The following is a description of a gene set: Genes up-regulated in comparison of untreated CD4 T cells at 0 h versus the untreated cells at 72 h. The aim of this dataset was to study in detail the transcription kinetics initiated by cytokine IL-4 in early differentiation of Th2 cells. studied in species Homo sapiens from publication Elo LL, Järvenpää H, Tuomela S, Raghav S, Ahlfors H, Laurila K, Gupta B, Lund RJ, Tahvanainen J, Hawkins RD, Oresic M, Lähdesmäki H, Rasool O, Rao KV, Aittokallio T, Lahesmaa R (PMID 20620947) Human Gene Set: GSE17974_0H_VS_72H_IN_VITRO_ACT_CD4_TCELL_UP, and this is the list of marker genes: ZNF844, HABP4, COQ10A, RFX3, CCDC86 (coiled-coil domain containing 86), C6orf226, GSAP, NFKBIZ, EGR1, ZNF394, ST3GAL5, SHISAL2A, MIR22HG, IL7R, MARCHF2, RNF11, SAMD4B, LGI1, ZDHHC11, CD83, RMND5A, PSMG4 (NCBI Gene Id 389362), ZBTB20, PRKCQ-AS1, ASAH1, HES4, RNF139, EID3, VCPKMT, TRPM7, WDR81, VIPR1, CLASRP, G0S2, LDB2 (NCBI Gene Id 9079), ST6GALNAC1, CXCL1, IPCEF1, TWNK, TSSC4, TTC28, FBXO33 (F-box protein 33), PRRX1, FCN1, SNX29, ITGA6, DNAJB9, TTN, TRIB2, MEF2D, PAIP1, CHD9, C16orf54, NSMCE3, CRAMP1, MAN2B2, RARS2, ITFG2, BIN2, PTPN13 (NCBI Gene Id 5783), TRAPPC14, SLC25A33, TRIB1, CTSO, TWF1, TNRC6B, NOSIP, PGAP3, APOBEC3A, VPS9D1, TRMT6, CLEC7A (NCBI Gene Id 64581), KRT73, ZNF669, TMEM132B, WDR53, EFHC2, MAP3K5, AK5, DGKQ, FBXL5, KANSL2, SOX6, CUX1, POLR3E (RNA polymerase III subunit E), ZNF256, TCTA, SMCR5, ATXN1L, DDX28, SNORD104, TENM1, METAP1D, TMEM9B, TNFSF8, ATP2B1-AS1, ZNF8, SMURF2, FCMR, USF3, CSGALNACT1, CIRBP, ITPRIP, SAXO5, GABBR1, MFSD1, KLF2, FHIT (fragile histidine triad diadenosine triphosphatase), UTP15, TSPYL4, YRDC, LILRB2, ENC1, PCSK5, YPEL5, NAP1L5, JUN, KLF11, TCF7L2, COQ10B, KLF4, IL1B, MORC2-AS1, LMTK2, ANKRD36C, RAPGEF1, SLC5A6, TPM2, IL11RA, LINS1, SGK1, ZNF592, ATP6V0A2, ANXA1, ERP27, FAM200B, C9orf78, TSPYL2, ENSG00000274253, STXBP5, SIK1, TAMALIN, PLXDC1, RNF125, SKIL, RAP1GAP2, ZNF542P, IRS2, IFT20 (intraflagellar transport 20), SYNM, PTP4A1, ZNF805, ZNF502, RRN3P1, RIOX1, ABHD13, LYZ, H3C1, L3MBTL3, LETM1, RNF10, ID2, AUTS2, ARIH2, TMEM201, SLC12A9, JADE1, RGS2, EPHA4, NR4A2, GABARAPL1, ARMC2, GADD45A, ANKRD52, TIGD1, FGF5, NOM1, TRIM16L, MARCHF8, TNFRSF21, ASPH, SLC25A25-AS1 (NCBI Gene Id 286208), DUSP1, HCK, PITHD1, ABL2, SNORA28, GPR153, PARP8, DGCR11, DNAJC3, INTS15, IER2